Given this list of marker genes GRM3, GRM6, GRM7, GRM1, GRM8, GRIK3, GRM2, GRM5, GRM4, here is a description of the gene set: Human Gene Set: GOMF_G_PROTEIN_COUPLED_GLUTAMATE_RECEPTOR_ACTIVITY species: Homo sapiens Combining with glutamate and transmitting a signal from one side of the membrane to the other by activating an associated G-protein, initiating a change in cell activity.